Given this list of marker genes TAOK3, SELENOP, CHST3, HEPN1, CSMD2, AQP4, QKI, PAX7, WFS1, PMP2, PDLIM3, CFAP44, NES, HS6ST2, ADAMTS6, DSC3, KCNN3, SOX1, OSBPL6, PLPP3, AK4, MCC (NCBI Gene Id 4163), FGFBP3, POU3F2, NKAIN4, CST3, POU6F1 (NCBI Gene Id 5463), LIX1, IFI44, MASP1, KCNQ2, CSMD3, NOTCH1, RFX4, GRIA1, NTRK2, HES1, PLCD3, CHD5, RIPOR2, TGFB2-OT1, CENPN, NACC2, LIFR, HSPB1, PBXIP1 (PBX homeobox interacting protein 1), SLC25A18, EFHC2, PMP22, DDAH1, FAT1, CCND2-AS1, SENP3, CIMAP3 (ciliary microtubule associated protein 3), SEMA6A, MPC1, BCAN, F3, FABP5, PDLIM5, IFI44L, GAB1, ZMAT1, STK33, DNAH7, MFGE8 (NCBI Gene Id 54740), ADGRG1, AAMDC, GABBR2, YAP1, ASIC3, HDAC4, DCLK2, NCAN, STON2, REST, SCUBE2, TIMP4, RIDA, LIPG, ODAD1, LRATD2, TRIM59, CREB5, RABL6, C8orf34, WWC1, ZBTB2, SOX9 (SRY-box transcription factor 9), NUF2, MNS1, GAREM2, ATP1B1, TCERG1L, TACC3, KIRREL3, NOTCH2, TIMP3, SGO2, CEP126, ATP13A4 (NCBI Gene Id 84239), MYORG, LRRC37A3, CA12, TCF4, ATP1B2, HES5, MAML2, LITAF, SMOC1 (NCBI Gene Id 64093), PARD3B, GLIS3, SEL1L3, SRI, IRX2, HBA2, TTYH1, CABIN1, KIF14, KCNJ1, MT1F, LIMCH1, CMTM4, MPZ, CCDC144A, WFDC1, YBX3, LTBP1, NSMF, PDPN, PIAS2, ARHGEF26, SESN3, ATP1A2, COLQ, COL27A1, EGR2, SLC1A3, EDNRB, DNAAF1 (dynein axonemal assembly factor 1), VSTM4, ZNF682, ARAP2 (NCBI Gene Id 23278), FAT3, SPRY2, ENPP2, SPECC1, TSPAN7, HBG2, HEPACAM, LUZP2, BRCA1, GBX2, GNG7, CPNE2, ZFP36L2, IQGAP2, COL4A5, NADK2, RBMS2, MTTP, SCD (stearoyl-CoA desaturase), NFIB, INPPL1, MGST1, CTDSP1, DSEL, RASSF2, CTNND2, GPR137B, CSGALNACT1, MRC2, CDH13, DPP6, C21orf58, CFAP210, CCN1, TNC, RACGAP1, SOX8, SPATA6, SHISA3, CRB2, KRT17, SLFN13, PAX3, NFIA, KIF23, FGFR3, IGSF9B, MTSS2, GRID2, SPMIP6, TNS1, RFTN2 (NCBI Gene Id 130132), ADGRB3, TPX2, GOLGA8A, BCAP29, TMT1A, PDE4C (phosphodiesterase 4C), SOX5, QDPR, FASN, SPAG1, SLC39A12, GINS1, MLC1, DNAJB1, MIR9-1HG, ILDR2, VEPH1, ASCL1, NDP, SLC1A2, MMD2, NDRG2, ADGRB2 (NCBI Gene Id 576), SCD5, ELOVL2, TSPAN18, LRRN1, FANCI, PHYHIPL, AIF1L, BCL6, ATP2B4, SALL1, ZFAND2A, LRRC4C, KIF15 (NCBI Gene Id 56992), GNG12, SERINC5, ARHGEF6, PEA15, PTCH1, SERPINE2, SLC7A11, KRT5, TF, OBSL1, NKX2-2, DBI, INKA2, ARHGEF4, CDK1, PCDH1, SLC6A9, HAS2 (NCBI Gene Id 3037), WNT7B, SPAG17, GJA1, ADCYAP1R1, SOX2-OT, LRRC17, HEATR5A, BARD1, FGF1 (fibroblast growth factor 1), FHL1, BUB1B, COL11A1, NLGN4X (NCBI Gene Id 64642), HBB, RGMA, FZD2, ERF, CDCA8, ITGB8, LRP1 (LDL receptor related protein 1), NDNF (neuron derived neurotrophic factor), DTX4, PREX1, GFAP, METRN, ROBO3, RSPH4A, HSDL2, FAM181B, TNFRSF11B, LRP2, KRT14, SLC4A4 (solute carrier family 4 member 4), WLS, LYPD1, C17orf67, NRARP, DNAH6, FOXJ1, ADAMTSL4-AS1, ESCO2, OMG (NCBI Gene Id 4974), HBG1 (NCBI Gene Id 8047), CCDC17, CRYAB (NCBI Gene Id 1410), LFNG, TNRC18, KLF15, KIF11, LRRC4, VCAM1, CMTM5, SDC3, ANOS1, ITPKB, FAT2, SPARCL1, CDR1, AFF2, KLF9, CCDC8, SERPINH1, HYDIN, HSPA6 (heat shock protein family A (Hsp70) member 6), ITGA6, ACSL6, ETV1, TAF1C, OPHN1, EPB41L4B, UBL3, SALL3, KANK1, TRIL, EEPD1, NPAS3, PLIN3, EGFR (epidermal growth factor receptor), VWA3A, PRDM13, IQCA1, C6orf118, SCN1A, ID4 (inhibitor of DNA binding 4), EGR1, PEAK1, GPM6B, IRX1 (NCBI Gene Id 79192), CNMD, FOS, CYP26B1 (cytochrome P450 family 26 subfamily B member 1, NCBI Gene Id 56603), FLJ16779, HBA1, LAMA5, IGFBP2, EPHA3, SLITRK2, INHBB, IFI6, GDPD2, HSPA7, XYLT1, SEZ6L, ALDH6A1, TGIF2, HEY2, SOX2, NPTXR, PBK, KIF2C, IFI27L2, KCNE5, PHGDH, ZFP36L1, CSPG5, PXDC1, JAM2, LRIG1, ACBD7, MT3, PDE1C, GRM3, RANBP3L, GABRG1, SRGAP3, ATP2B2, GATM, SFRP2, ITGB5, EFHD2, SPRED1, ERVK13-1, ACSS1, CDC25C, PIF1, CENPE, CITED1, PTF1A, BIRC5, NFIX, TCF7L2, DEPDC1, GPC4, ENHO, AKAP7, TSC22D4, NTRK3, MYBL2, NCKAP5, PTPRZ1, NFATC2, SOX21, ELN, DPF3, BTN3A3, NCAPG, ZNF83, WNT7A, DBX2, FAM167A-AS1, CSPP1, CCDC146, GPX8, PRKD3, PTN, PLP1, DENND2B, TNK2, WDR93, NUSAP1, H2AX, SNCAIP, C2orf72 (NCBI Gene Id 257407), ITPR2, ABAT, BCLAF3, VIM, IRX4, PON2, SGO1, GPC1, AHNAK, MKI67, JUN, AURKB, WSCD1, RTKN2, BOC, XRCC3, KIF1A, here is a description of the gene set: from publication La Manno G, Gyllborg D, Codeluppi S, Nishimura K, Salto C, Zeisel A, Borm LE, Stott SRW, Toledo EM, Villaescusa JC, Lönnerberg P, Ryge J, Barker RA, Arenas E, Linnarsson S (PMID 27716510) studied in species Homo sapiens Human Gene Set: MANNO_MIDBRAIN_NEUROTYPES_HRGL2B Cell types are named using anatomical and functional mnemonics prefixed by 'm' or'h' to indicate mouse and human respectively: OMTN, oculomotor and trochlear nucleus; Sert, serotonergic; NbM, medial neuroblast; NbDA, neuroblast dopaminergic; DA0-2, dopaminergic neurons; RN, red nucleus; Gaba1-2, GABAergic neurons; mNbL1-2, lateral neuroblasts; NbML1-5, mediolateral neuroblasts; NProg, neuronal progenitor; Prog, progenitor medial floorplate (FPM), lateral floorplate (FPL), midline (M), basal plate (BP); Rgl1-3, radial glia-like cells; Mgl, microglia; Endo, endothelial cells; Peric, pericytes; Epend, ependymal; OPC, oligodendrocyte precursor cells.